The following is a description of a gene set: studied in species Mus musculus from publication Chen Y, Wang X (PMID 31504780) Mouse Gene Set: MIR_1981_5P Genes predicted to be targets of miRBase v22 microRNA mmu_miR_1981_5p in miRDB v6.0 with MirTarget v4 prediction scores > 80 (high confidence targets)., and this is the list of marker genes: Vcl, Zfp52, Zfp386, Polr1b, Accs, Reep1, Fgfbp3, Abracl, Mapk4, Sox18, Ikzf5, Cxcl3, Slc25a53, Nlrp10, Tra2a, Ythdf3, Igf2r, Rwdd3, Dag1, Slc34a2 (solute carrier family 34 (sodium phosphate), member 2), Orc2, Slf2 (SMC5-SMC6 complex localization factor 2), Rbfox2, Klhl23, Sox17, Glb1l3, Degs2, Stom, Peg3, Rap1b, Dpy19l1, Itsn2, Trem5, Klhl24, B3galt1, Etv3, Brd4, Rit2, Uqcrq, Mical2, Mettl21e, Sap18b, Ssr1, Fam177a2, Vapa, Hdhd2, Rab3gap2, Tle1, Ccdc88a, Taf1, Becn1, Plp2 (NCBI Gene Id 18824), Psg25, Myo1e, P3h4, Svip, Palld, Oxct1, Klhl42, Nup50, Gata2, Sestd1, Tnrc6b, Slc25a28, Spire1, Bex3, Zfp62, Tsen54, Seh1l, Rab5b, Zfx, Rtkn2, Carmil1, Celf6, Ino80d, Cd9, Ppp1r11, Hectd2, Mlf2, Hspa9, Wtap, Gid4, Snx18, Mier3, Zbtb33, Jazf1, Thnsl2, Alg9, Ppargc1a, Cdc37l1, Ppp1r3d, Nipa1, Cdc5l, Ntsr1, Atp1b2, Usp15, Gata3, 2310022B05Rik, Mis18a, Ptprk, Kif26a, Abhd2, Mmd, Lbr, Fzd4, Gm11545, Lactb, Nfatc2, Zfp493, Dennd4a, Ago3, Gprc5b, Maoa, Tmem106b, Ddx3x, Ppfia2, Mre11a, Zmpste24, Usp45, Tead1, Phtf2, Ncbp2, Rnf6 (NCBI Gene Id 74132), Nxpe2, Zfp937, Lrp11, Mysm1, Spout1, Fam177a, Gm17019, Tmem132d, Ncam1, Galnt1, Ing3, Tshz3, Rora, L2hgdh, Idua, Igf2bp3, Calu, Zfp955a, Aldh1a3, Thsd1, Nrip3, Papola, Pappa, Tra2b, Crip1, B3galt2, Lrrc7, Rcn2, Tulp4, Pard3, B3galnt2, Cby1, Osbpl8, Qser1, Rere, Usp37, Gm9758, Snx30, Gabpb2, Lrrc41, Tbc1d8, Rfx3, Sos1, Gja6, Plekhh1, Ccsap, Uba2, Rimklb, Zfp850, Sp1, Mms19, Zmynd11, Pak5, Bhlhe40, Ncapg2, Rhbdd2, Phc3, Dipk2a, Pde2a (phosphodiesterase 2A, cGMP-stimulated), Smg7, Ago4, Elavl1, Mettl2, Plcb1, Fundc2, Gatad2a, Nkiras1, Padi1, Retnla, Wnk3, Tfr2 (NCBI Gene Id 50765), Eif4a2, Nrn1, Vipr2